Given this list of marker genes AGPAT1, ADAMTS9, YPEL3, WNK2, INKA2, PRSS8, KCNS2, SSBP2, MTF2, NKAIN4, RNU6-362P, C18orf21, NDFIP1, DNAH14, SLC44A2, HTR1A, EVL, C3orf70, ENSG00000201465, PSMC5, DUSP22, WNT2B, TTLL3, CBR1, ENSG00000207147, SLC25A23, VWA8, SMARCD2, LHX4, OAS2, PCNX1, GNAS, FA2H, STX16, MT-TL2, BZW1-AS1, METAP1, PRKAR1B-AS2, SIGLEC22P, ARHGAP31-AS1 (NCBI Gene Id 100874246), ATP2C1, TBC1D13, KRBA1, RN7SKP150, SEC14L5, TKT, LINC01711, RN7SKP140, LNROP, MCFD2, RNVU1-27, E2F6P4, PLCE1, NMUR1, ENSG00000267882, ZFP30, MT-TL1, ST6GALNAC1, SNHG33, MT-ND6, MBTPS1, GUSBP1, PDIA6, RAB27A, GPER1, DPY19L4, PRELID3BP11, C11orf68, KIAA1549, ENSG00000267058, CFI, SH2B1, PHLDA3, ARID1A, MT-ND3, WASL-DT, PKMYT1 (protein kinase, membrane associated tyrosine/threonine 1), ACIN1, MT-TM, TMPO-AS1, RNU5B-1, MINDY1, OSBPL9P5, ENSG00000267448, ASPG, PHF12, BARHL1, FSCN1, WASL (WASP like actin nucleation promoting factor), TMCC1-DT (NCBI Gene Id 100509280), ATP9A, RPL39P39, CCDC159, SRRM3, IGHV3-30-2, SGTA, SEPTIN9, CUEDC1, KCNH1, YDJC, INTU, SMYD3, ZNF284, FADS2, GNA12, ST20, HECTD1, CFAP410, CDKL3, MT-TI (mitochondrially encoded tRNA-Ile (AUU/C)), ZCCHC4, TBPL2, CRTC1, WSCD2, MIR5194, WFDC1, ENSG00000259881 (NCBI Gene Id 101927793), MIR100HG, RPL36AP30, VN1R38P, ZNF586, DTWD2, SAPCD2P1, TBX4, MT-TS2, PAK1, ARFGEF2, FAM222A-AS1, RNY1P2, LINC01750, TTC14-DT, DEF8, PRKAR2B, FLVCR2, FABP5P3, ATP6V1G1P6, HDLBP, MIR199B, RNU6-859P, MICAL3, PSMC1, GFM2, ZNF683, OPLAH, HSPG2 (heparan sulfate proteoglycan 2), NPAS2, RPL12P28, PRKAG2, WDR90, SLC22A7, NAXE, CD74, KRT5, PCSK6, RNU6-236P, PCNX3, PDE11A (phosphodiesterase 11A), SNRPB2, LINC02564, OLFML2B, LRRK1, LMTK3, CNDP1, TSNARE1, ZNF740, MIR1193, POLE4, SYF2P2 (NCBI Gene Id 100128275), OSBPL2, FAM153CP, TPT1P15, ZNF808, ADGRB3, MT-TG, SNORA70G, RN7SKP237, NUP210, LINC00944, ASAP1, RFTN1, GOT2, MRPL3, ZNF529 (zinc finger protein 529), FMC1, PDZK1, MAN2A1, DRAP1, WDFY1, IFIT2 (interferon induced protein with tetratricopeptide repeats 2), FRA10AC1, KRT18, PCSK6-AS1, BCL7A, CALCRL, ZNF833P, ENSG00000252143, KMT2E, CEP85, PREX1, SLC39A11, CDC16, MOB1B, FAM20C (FAM20C golgi associated secretory pathway kinase), SUCLG2P2, ADGRB1, PLCG1, NIPAL1, PPP1R9B, ANKS3, MT-TF, FAAH, PRKCH, GLDN, PIP5K1A, MAPK6 (NCBI Gene Id 5597), TCEA2, TNFSF8, SULF2, ZNF16, LINC01898 (NCBI Gene Id 100509898), ZNF559-ZNF177, GPR85, ACTG1P12, KIAA0513, REV1, NECTIN1, PPM1B, CLPTM1L, ENTPD6, CHCT1, HTR5A, STAT1, NOC4L, DCLK1, ENSG00000240207, ANKS6, ZNF433-AS1, FABP6, MRPS5, RNVU1-19, MAN1B1, SERPINA1, CD47, RN7SL354P, MORN5, BPIFB4, ZNF501, EXOC4, PXK, ANKMY1, NRXN2, MAD1L1, LINC02436, PPCS, SNX14, MYO15B, TCF25, LUC7L2, VAC14, FRG1, PIGB, AGK-DT, CCDC187, KCNH1-IT1, WDR70, AHNAK, DDX51, CHKA, TLK1P1, RUNDC3A, ZC3H14, WDR27, RNA5SP90, KATNBL1, TEX11, SLC25A5, LINC01515, LINC00887, GPRIN2, LAMTOR5-AS1, LINC01579, CDC42P2, RAB40B, RNU7-90P, OSCAR, CASKIN2, RN7SL606P, ATF7IP2, ZNF561-AS1, CCL27, MCEE, ACTL8, BCAS3, AGPAT3, NPEPL1, DCAF4L2, PI4KB, ULK2, KDM1A, TRAM2-AS1, CRBN, LAD1, CCER1, SH3BP2, CARMIL3, RARG, ENSG00000179066, RPL18P10, FADS3, MIR6165, CDK5RAP1, MT-TH, SMCO4, LINC00552, ZNF490, PGBD2, HMGN2P34, PDE9A, KRT8, ZMPSTE24, SPTAN1, DSCAM, SNAP47 (synaptosome associated protein 47), IGHVIII-25-1, GAPDHP66, MTR, DUX4L17, SBF2, OSBPL7, NSUN5, SLIT3-AS2, ENSG00000230226, SLC12A5, PACC1, TMEM204, ABHD13, MT-TT, RSL24D1P11, DPP6, LAMTOR5, NRF1, ADAP2, NEGR1, EEIG2 (NCBI Gene Id 284611), ZNF669, BDH1, CAMLG, FXN, ABCG1, TMTC2, JMJD4, ST6GAL1, KANSL3, CALB2, LINC01523, LINC00973, DMAP1 (NCBI Gene Id 55929), MICALL2, INPP5D, TMPRSS3, FGD3, LINC02868, CAD, LAMB4, RPL36P6, TRIM67, PTTG1IP, MTMR9, LRRC59, SERPINB1, LINC00701, LINC01535, DLK2, C18orf21P1, DGKG, ENSG00000238440, CHFR, RPS3AP18, HSALR1, LINC00479, LINC02945, ZNF687, TRABD2A, DHTKD1, PLLP, COX6CP3, GLRA1, SOCS6, RPL23AP53, PC, SLC13A3, SUN1, HECW2, GYG2 (NCBI Gene Id 8908), ELOVL2, MRPL40, CDC14B, LZTR1, FBXO22, RCHY1, RABGAP1, DOCK6, ACTN2, ZNF263, C1orf159, WIF1, ATP5MJ, LINC01960, STEAP1B, FRG1-DT, KIAA1958, PORCN-DT, ZNF570, LTBP2, TARS2, SELENBP1, ESRP2, MUC6 (mucin 6, oligomeric mucus/gel-forming), GGA1, LINC02422, CORO1A (coronin 1A), EPS8, RESF1, COMTD1, KLC1, KAT6A, ZNF280B, RNU1-22P (NCBI Gene Id 100873863), LINC01164, ETNK2, ZCCHC2, TOP1MT, BICDL1, FAM98B, SEMA4D, PSMD7-DT, STMP1, ZNF341, DHX38, JADE1, WDR36, H3P42, ZMYND12 (zinc finger MYND-type containing 12), BZW1, PDE12, TRIB1, ZNF114 (NCBI Gene Id 7667), BSDC1 (NCBI Gene Id 55108), IMPACT, THUMPD1, MTIF2, BMP7, DGAT1, RNF10, EXD3, COL5A1, CORO7, PTGFRN, RPL10P12, ZNF596, TWF2-DT, FGFR4, ANAPC15, ENSG00000199470, SLC25A6P5, C1GALT1, RN7SL824P, AK3P2, CIAPIN1, REPIN1-AS1, PPP2R2A, SLC25A6P1, TULP2, PCBP3-AS1, ALG10B, FTSJ3, AHRR, CYP1B1-AS1, VMA21, APBA1, YWHAQ, KMT2C, ADAT2, SCN1B, ITGAV, MT-RNR1, IKBKB-DT, CLSTN1, TTC7A, LINC02369, MT-ND5, PACS1, PSMG3-AS1 (NCBI Gene Id 114796), MIR4273, SYN3, RIPOR3-AS1, LAMB1, TCEA1, ABHD12, R3HCC1, PLD4, GAREM1, ACTR1AP1, ACOT9, MT-CO3, MYLIP, NOS3, PSME1, ZNF264, DQX1, INTS12, SPTBN4, PDGFRB, ENSG00000231083, VN1R7P, H1-1, ARL8B, PIEZO1 (piezo type mechanosensitive ion channel component 1 (Er blood group)), ZNF875, RNA5S12, CHCHD2, TNFRSF10C, CD300A, OSMR, METTL9, FEM1C, RNU6-563P, LINC01429, ZMYND11, KLK2, ENAM, GUSBP2, IGHMBP2, ZNF420, NOXA1, PRELID3B, JPX, DNM2, RPF1, HIRA, AGK, ATXN7, MRNIP, SRXN1, CPN2, VWA8-AS1, FAM218A, PACS2, AOC1, FGFRL1, KSR1, DDX11L5, FLJ16779, PRICKLE2-AS3, RNU6-1158P, LAMP1, RNU4-71P, OBSCN-AS1, CEP85L, RPTOR (NCBI Gene Id 654218), ATP23, ASB13, ZNF391, TSEN15, TBC1D3P1 (TBC1 domain family member 3 pseudogene 1), LINC02593, TRMT44, EHD1, MIR218-2, WDR59, LINC01522 (NCBI Gene Id 101927457), MEG3 (maternally expressed 3), SNORD115-3, ZNF766, UTP3, ZNF566-AS1 (NCBI Gene Id 731815), CPLANE1, BTBD2, MIR7-3HG, ZBTB40, LINC02953, SHANK2-AS3, GCGR, MGRN1, IRGM, CSTP1, ZNF605, GOLM2P1, MAP7D2, DOCK8, SHMT1, CHRM1, PIGZ, THOC1, CPSF1, MIR3154, NKX6-3, SSR1, ZNF559, RHBDF1, MIDEAS, LINC02142, RUNDC3A-AS1, LIG4, ADNP, SLC24A1, TPTEP1, FAM3C, USH1C, EXOC3L4, UNC13A, ZNF236-DT, TEFM, ST7, DSTYK, RN7SL592P, PCID2, NUP188, ZNF846, SLC29A3, ZNF561, EP400, ARHGAP39, TUFT1, TPK1, LNCATV, EPB41L4B, AKR1C3, MROH1, GALNT2, ELOVL2-AS1, EPN3, GSTCD, RMND5A, CRIPTOP4, ZEB2, RNF14P1, RAN, ENSG00000250685, RPS7, LZTS2, PMFBP1, LRRC37A15P, PRAMENP, CDAN1, XYLT2, LINC00494, SLC7A1, MT-ND2, ADTRP, ENSG00000200222, SLC8A2, TMEM41A, RNU6-1310P, DNAJB8, ITGB4, FSIP2, SELENOH, ARHGAP32, PRSS2, RNU6-1000P, AMN, CHCHD2P1, SAR1A (NCBI Gene Id 56909), ALG10, DNAAF5, LHX2-AS1, ENSG00000266088, GPT2, AGGF1, CARD14, GTF3C3, THBS3, HNF1A, EFCAB8, NFE2L2, RPRD1A, TNNI3, PLEC, LY6H, UBE4A, LINC00240, ITGB2-AS1, ZC3HC1, NAPEPLD, LINC00304, NGEF, PSMG3, RNU6-994P (RNA, U6 small nuclear 994, pseudogene), CFAP46, RAP2C-AS1, THADA, PRIM2, ZNF426, RCL1, SELENOW, FMR1, DENND3, RTEL1, LINC02212, MUC20-OT1, USP10, RPS6KB2, SCRN2, MIR4737, FGF10-AS1, CHRNA4, GIPR, TTC14 (tetratricopeptide repeat domain 14), B3GNTL1, STX16-NPEPL1, SLC38A2, RNA5SP528, ZFAT, SVOP, MYEOV, VN1R2, TBC1D3P1-DHX40P1, BLVRB, LRRC37A3, CNTN2, USP32, PXMP2, PORCN, LRIG1, TRIM37, INTS14, CUL4A, SAMD4B (NCBI Gene Id 55095), MMRN2, AP3S2, CCDC69, RNVU1-34 (RNA, variant U1 small nuclear 34), KRT8P46, MAN2B2, CEBPB, ENPP3, TSPOAP1, SORD2P, SLC44A1, SLX9, POLR1F, SRMP1, ZNF395, ZNF138, DENND1B, LRCH4, ATP1A1, MTERF1, PPP4R4, MCCC1, POLE, BCAT1, ALKBH3, RNU5A-1, ZNF286A, ZMPSTE24-DT, PRPF39, VPS4A, MIR142HG, GSPT1, DDX11L17, ERFL, SMG8, BOP1, ZNF701, MINCR, ZNF569, MIS18BP1, EPHX2, KMT5C, SLC25A5-AS1, CCNC, RN7SKP115, R3HDM2-DT, DYNC1H1, KCNQ2, NKD2, FOXJ3, USP3, LINC02392, NUDT14, CCT6P3, RAE1, GMDS-DT, SYBU (syntabulin), KLHL20, MT-TE, LINC02418, CICP12, RRAS2, COA1, NAALADL1, XCR1, RNVU1-14, EPS15, CDH15, RIOX2, TACC3, BCAR1 (BCAR1 scaffold protein, Cas family member), ACTE1P, RNU6-1138P, GYPA, GNE, ROBO3, GPAT4, PRICKLE2, SP7, PRLH, NCOA3, MIR7-3, ZSCAN31, ITGB2, RPL13AP8, WIPI1 (WD repeat domain, phosphoinositide interacting 1), DIP2A, STKLD1, SURF4, SNX19, PEX3, REEP3, RAP2C, PIGBOS1, MROH3P, TTI2, PRDM4, GET1P1, RIPOR3, RPL22, DNAJC19P2, C2CD2, PRICKLE2-AS1, PPIL2, TMEM229B, TNFSF14, R3HDM2, TMEM179, ZNF404, SNHG7, EML3, FAM133B, ZNF536, MAPK13, NSA2, PMPCA, ZNF737, ANKDD1A, INF2, CHD2, RPL15P15, NOC3L, MIR3189, CYTH1, GRM4, UBE2QL1, MIR4323, SYNPR, MED23, CCAR2, TMEM39A, LINC01671, RPS6KL1, MAN2A1-DT, COX16, LINC03068, DUS3L, LRRC27, MIR6775, MT-TP, ZNF609, NOD2, TRAM2 (translocation associated membrane protein 2), IGHV3-11, GDF15, TBC1D28, NIT2, CAPS2 (calcyphosine 2), MTRFR, COP1P1, PLAC9P1, SIAH1, ATP8B3, TRIM25, C1QTNF1 (C1q and TNF related 1), here is a description of the gene set: Human Gene Set: CBX5_TARGET_GENES studied in species Homo sapiens from publication Yevshin I, Sharipov R, Kolmykov S, Kondrakhin Y, Kolpakov F (PMID 30445619) Genes containing one or more binding sites for (CBX5) in their promoter regions (TSS -1000,+100 bp) as identified by GTRD version 20.06 ChIP-seq harmonization.